The following is a description of a gene set: studied in species Homo sapiens Aplasia of the nail. Anonychia Human Gene Set: HP_ANONYCHIA, and this is the list of marker genes: ERI1, KCNH1, DLL4, PIGP, ATP2A2, DSP, GJB6, ARHGAP31, EOGT, PLEC, SLC25A22, GRIN1, LAMC2, TBC1D24, PIGQ, CRKL, CASK, JUP, RBPJ, SIK1, MAPK1, ARX, NOG, SCN1B, PIGF, ROR2, RSPO4, COL7A1, ZBTB20, KCNN3, RIPK4, APC, ARID1A (AT-rich interaction domain 1A), MMP1, GRHL2, GRM7, NEUROD2, NOTCH1, LMX1B, LAMA3, RBBP8, TP63, FIG4, SCN2A, GPC4, ITGB4, SLC25A24, PORCN, ACTG2, GNAO1 (NCBI Gene Id 2775), CDKL5, BCR, DMXL2, KCNA1, LRP4, SLC32A1, WNT7A, ARID1B, KRT14, DOCK6, LAMB3, COL17A1, ATP6V1B2, TRIM8 (NCBI Gene Id 81603), WNT10A, PNKP